Given this list of marker genes PTTG1, NAPA-AS1, CAV2, TPX2, CXCL1, CDK1, H3C4, TAF6L, THTPA, NUCKS1, E2F3, MT1B, THBS1, USP32, FST, THBD, H4C2, IGF2, PTMA, BAIAP2L1, TIMP3, MAL2, RRM2, LPL, KRT80, LBR, PCNA, PLK1, H2AC25, INHBA (NCBI Gene Id 3624), VIM, H3C6, MAD2L1, NFKBIA, MT1X, MT1H, MT1F, H1-2, MYBL2, here is a description of the gene set: Amplification and overexpression of the E2F3 gene at 6p22 in human bladder cancer is associated with increased tumour stage, grade and proliferation index, and in prostate cancer E2F3 overexpression is linked to tumour aggressiveness. We first used small interfering RNA technology to confirm the potential importance of E2F3 overexpression in bladder cancer development. Knockdown of E2F3 expression in bladder cells containing the 6p22 amplicon strongly reduced the extent of bromodeoxyuridine (BrdU) incorporation and the rate of cellular proliferation. In contrast, knockdown of CDKAL1/FLJ20342, another proposed oncogene, from this amplicon had no effect. Expression cDNA microarray analysis on bladder cancer cells following E2F3 knockdown was then used to identify genes regulated by E2F3, leading to the identification of known E2F3 targets such as Cyclin A and CDC2 and novel targets including pituitary tumour transforming gene 1, Polo-like kinase 1 (PLK1) and Caveolin-2. For both bladder and prostate cancer, we have proposed that E2F3 protein overexpression may cooperate with removal of the E2F inhibitor retinoblastoma tumor suppressor protein (pRB) to drive cellular proliferation. In support of this model, we found that ectopic expression of E2F3a enhanced the BrdU incorporation, a marker of cellular proliferation rate, of prostate cancer DU145 cells, which lack pRB, but had no effect on the proliferation rate of PC3 prostate cancer cells that express wild-type pRB. BrdU incorporation in PC3 cells could, however, be increased by overexpressing E2F3a in cells depleted of pRB. When taken together, these observations indicate that E2F3 levels have a critical role in modifying cellular proliferation rate in human bladder and prostate cancer. Genes down-regulated in the 5637 cell line (bladder cancer) after knockdown of E2F3 by RNAi. from publication Olsson AY, Feber A, Edwards S, Te Poele R, Giddings I, Merson S, Cooper CS (PMID 16909110) Human Gene Set: OLSSON_E2F3_TARGETS_DN species: Homo sapiens